The following is a description of a gene set: Pathway Definition from KEGG: CDKN1B* // (CCNE+CDK2) -> RB1 // E2F Human Gene Set: KEGG_MEDICUS_VARIANT_LOSS_OF_CDKN1B_TO_P27_CELL_CYCLE_G1_S Loss of CDKN1B to p27-cell cycle G1/S. Pathway ID: N00093. Pathway type: Variant. Pathway class: nt06272 Prostate cancer. studied in species Homo sapiens, and this is the list of marker genes: E2F1, RB1, CCNE1, E2F3, E2F2, CCNE2, CDK2, CDKN1B